Given this list of marker genes PMPCA, IMMP2L, IMMP1L, MIPEP, PMPCB, SIRT4, LRRK2, here is a description of the gene set: The cleavage of peptide bonds in proteins, usually near the N terminus, contributing to the process of import into the mitochondrion. Several different peptidases mediate cleavage of proteins destined for different mitochondrial compartments. studied in species Homo sapiens Human Gene Set: GOBP_PROTEIN_PROCESSING_INVOLVED_IN_PROTEIN_TARGETING_TO_MITOCHONDRION